Given this list of marker genes Gm32005, Setd6, A330008L17Rik, Gm31659, Gm26265, Gm25160, Mir7073, Slc38a7, Ndrg4, 9430099M06Rik, Gm17997, Cnot1 (CCR4-NOT transcription complex, subunit 1), Gm26493, Gm39231, Gm5361, Cdh11, Gm8730, Gm5131, 1700047G07Rik, Gm22223, Gm23494, Got2, Sap18b, Gm39232 (predicted gene, 39232), Gm32122, Gm19232, Gm5913, Impdh2-ps, Cdh8, Gm7191, Gm8688 (NCBI Gene Id 667531), Gm5742, 4930513N10Rik, Gm31805, Gm7192, Gm15681, Gm8637, Gm15679, Gm6013, Gm29817, here is a description of the gene set: Mouse Gene Set: chr8D1 species: Mus musculus